The following is a description of a gene set: Mouse Gene Set: GOMF_PYRIMIDINE_NUCLEOTIDE_SUGAR_TRANSMEMBRANE_TRANSPORTER_ACTIVITY studied in species Mus musculus Enables the transfer of a pyrimidine nucleotide-sugar from one side of a membrane to the other. Pyrimidine nucleotide-sugars are pyrimidine nucleotides in glycosidic linkage with a monosaccharide or monosaccharide derivative., and this is the list of marker genes: Slc35a2, Slc35b1, Slc35d2, Tmem241, Slc35d3, Slc35d1, Slc35a1 (NCBI Gene Id 99967), Slc35a3, Slc35b4, Slc35a5